Given this list of marker genes Abhd17b, Ankrd13a, Dtx3l, Abhd17c, Egf, Rdx, Rock2, Msn, Ezr, Egfr, Zdhhc1, Nf2, Vegfa, Sorl1, Abhd17a (NCBI Gene Id 76403), Mgat3, here is a description of the gene set: Mouse Gene Set: GOBP_REGULATION_OF_PROTEIN_LOCALIZATION_TO_ENDOSOME Any process that modulates the frequency, rate or extent of protein localization to endosome. studied in species Mus musculus